The following is a description of a gene set: The chemical reactions and pathways involving cytidine, cytosine riboside, a widely distributed nucleoside. studied in species Mus musculus Mouse Gene Set: GOBP_CYTIDINE_METABOLIC_PROCESS, and this is the list of marker genes: Cda, Aicda, Pycr3 (NCBI Gene Id 67195), Cdadc1, Dctd